The following is a description of a gene set: Human Gene Set: WP_COMPLEMENTMEDIATED_INFLAMMATION_OF_PULMONARY_ALVEOLUS_IN_COVID19_HYPOTHETICAL_PATHWAY species: Homo sapiens Complement-mediated inflammation of pulmonary alveolus in COVID-19 (hypothetical pathway), and this is the list of marker genes: C3 (complement component 3), C7, C6, C3AR1, COLEC11, C5, MASP2, C8A, C9, FCN1, ACE2, C5AR1